The following is a description of a gene set: Human Gene Set: GOCC_CYTOSOLIC_SMALL_RIBOSOMAL_SUBUNIT studied in species Homo sapiens The small subunit of a ribosome located in the cytosol., and this is the list of marker genes: RPS15A, RPS4Y2, RPS25, RPS4X, DHX29 (DExH-box helicase 29), RPS27A, RPS28, RPS26, RPS2, RPS10P5, RPS4Y1, LARP4, RPS7, RPS17, RPS8, DDX3X, RPS18, FAU, RPS10, RPS27 (ribosomal protein S27), RPS9, EIF2A, RPSA, RPS29, RPS23, RPS3, RPS21, RPS27L, RPS15, RPS5, RACK1, RPS13 (ribosomal protein S13), RPSA2, RPS11, RPS3A, RPS19, RPS14, RPS12, RPS20, RPS24, RPS6, RPS16